Given this list of marker genes Tmem237, Zfp647 (NCBI Gene Id 239546), Per2, Itgal, Dock2, Ralb, Mycn, Lmo4, Chm, Lrmda, 5730471H19Rik, Arhgap30, Ppbp, Tuft1, Pdxk, Slc7a6, Kyat3, Cd27, Ccdc91, Wipf1, Pbx1, Cpq, Kctd11 (potassium channel tetramerisation domain containing 11), Cmtm7, Adamts20, Pde3b, Shmt1, Plp2, Lyplal1, Bcl7c, Tgm2, Bcl2l15, Tm6sf1, Siglecf, Zfp810, Rcn1, Lhfpl2, Mcpt4, Prtn3, Ttc8, Macroh2a1, Ptprs, Lgals1, Syk, Grb10, Tgfbr3 (transforming growth factor, beta receptor III), Ptprcap, Sqor, Slain1 (SLAIN motif family, member 1), Myct1, Arxes2, Pak1, Zc2hc1a (zinc finger, C2HC-type containing 1A), Cyfip2 (cytoplasmic FMR1 interacting protein 2), Plpp2, Nckap1l, Acap1, Nedd4l, Nqo2, Ptpn14, 4933431E20Rik, Bex6, Nr3c1, Nudt12, Lrrc56, Pdxp, Mndal, 4930403D09Rik, Nisch, AI504432, Celf2, Nubpl, Tmsb10, Pdlim1, Plxna2, Nck2, Pnpo, Lrch1, Prkd3, Cdc42ep3, Svil, Zfp979, Slc39a8, Dennd11, Ndst1, Rgs18, Cryl1, Ctbp2, Top1mt, 4933439C10Rik, Ube2e2, Hesx1, Cnn3, Fyn, Adgra3, Bex1, Rps6ka6, Cma1, Rcsd1, Ggh, Gk5, Gmfg, Tyrobp, Klhl5, Gp1bb, Cdip1 (cell death inducing Trp53 target 1), Iqgap2, Vim, Vegfb, Kctd14, Ift81, Zfp422, Gtf2ird1, Emb, Lrrc8d, E130307A14Rik, Dusp2, Mif (NCBI Gene Id 17319), Galnt7, Stap1, Smo, H2-DMa, Ptgr1, Arpc1b, Zfp704, Arrdc4, Zfp820, Fuca2, Bcr, Rgcc, Tjp2, Psmb9 (NCBI Gene Id 16912), Mei4, Septin11, Oosp2, Dock10, Ptprc, Lipa, Phpt1, Ptpn18, Lcp1, Sell, Ifi203, Prss50, Plac8, Runx3, Brca2, Eif4e3, Acot7, Skil, Pdgfd, Rgs19, Lats2 (NCBI Gene Id 50523), Spred1, Rassf5, Nlrc5, Hlf, Polr3g, Bckdhb, Slc25a13, Oaf, Susd2, Gm49083, Repin1, Il31ra, Mfsd6, Crlf3, Enc1, Sgpl1, Tpd52, Man2a2, Hook1, Ell2, Ralgps2, Ctps2, Capg, Marcksl1, Dcun1d4, Aqp11, Bmyc, Traf3, Arhgap15, Tspyl3 (NCBI Gene Id 99345), Bbs12, F5, Mpzl1, Phgdh, A630081D01Rik, Nab1, Rapgef2, Adgrg3, Magi3, 4930519L02Rik, Kifap3, Atxn10, F13a1, Gstm1, Gsta4, Mfsd13a, Pard6g, Ppp1r9a, Fchsd2, Nkg7, Tgif2, Cimap1b, Panx1, Mmd, Hk2, Bambi, Cbl, Sdc1, Socs5, Gng12, Lipo3, H1f0, Fkbp11 (FK506 binding protein 11), Alox12, Atxn1, Klhl22, Fkbp5, Sapcd2, Cd81, Pde4b, Smyd3, Endog, Dnmt3a, Zfp799, Rnf144a, Mob3a, Septin4, Syde2, Cdc14a, Gcnt2, Tspan3, Scml2, Slc25a4, Rhobtb3, Rmdn2, Plxnc1, Gimap6, Pitpnm2, Clec1b, Pde5a, Ggta1, Khdrbs3, Pdia2, Plcb4, Cntln, Krt10, Slc4a7, Kcnab2, Angpt1, Zfta, Tasl, Cenpw, BC035044, Cep68, Itgb3, Kctd1, Trib2, Homer2, Zfp455, Meis1, Adgrl2, Ccnd1 (NCBI Gene Id 12443), L3mbtl3, Ccl9, Tpk1 (thiamine pyrophosphokinase), Ctsc, Itprid2, Scmh1, Oxct1, Maoa, 4933405D12Rik, Ccnyl1, Smim36, Psmb8, Iftap, Tnfrsf13b, Fkbp1a, Smco4, Dock9, Gt(ROSA)26Sor, Ccdc122, Agpat2, Ltbp1, Dach2, Setmar, Itm2a, Cpne3, Gstt2, Atp8b4, Gpr171 (NCBI Gene Id 229323), Jcad, Ccdc69, Zfp518b, Igfbp4, Cavin2, Selplg, Rere, Limd2, Epb41l2, Mef2c, Gjb2, Fgfbp3, Sox4, Smim13, Ifngr1, Zkscan17, Satb1, Kctd12, Sh3tc2, Lclat1, Brpf3, Lst1, Itpr1, Hpcal1, Egfl7, Tns3, Slc38a1, Pxylp1, N4bp2l1, Ptpn3, Zfp2, Tspan6, Tdrkh, Il1bos, Hoxa9, Rsad1, Wwc2, Zscan18, Cnn2, Dnmt3b, Ctdspl, Pdia5, Ube2d1, Cd34, Slc6a13, Igf2bp3, Hmga2, Ncf2, Septin6, Map4k4, here is a description of the gene set: from publication Torchia EC, Boyd K, Rehg JE, Qu C, Baker SJ (PMID 17875932) studied in species Mus musculus EWS/FLI-1 is a chimeric oncogene generated by chromosomal translocation in Ewing tumors, a family of poorly differentiated pediatric tumors arising predominantly in bone but also in soft tissue. The fusion gene combines sequences encoding a strong transactivating domain from the EWS protein with the DNA binding domain of FLI-1, an ETS transcription factor. A related fusion, TLS/ERG, has been found in myeloid leukemia. To determine EWS/FLI-1 function in vivo, we engineered mice with Cre-inducible expression of EWS/FLI-1 from the ubiquitous Rosa26 locus. When crossed with Mx1-cre mice, Cre-mediated activation of EWS/FLI-1 resulted in the rapid development of myeloid/erythroid leukemia characterized by expansion of primitive mononuclear cells causing hepatomegaly, splenomegaly, severe anemia, and death. The disease could be transplanted serially into naïve recipients. Gene expression profiles of primary and transplanted animals were highly similar, suggesting that activation of EWS/FLI-1 was the primary event leading to disease in this model. The Cre-inducible EWS/FLI-1 mouse provides a novel model system to study the contribution of this oncogene to malignant disease in vivo. Mouse Gene Set: TORCHIA_TARGETS_OF_EWSR1_FLI1_FUSION_DN Genes down-regulated in leukemic progenitor cells expressing activated fusion of ESWR1 and FLI1 compared to normal hematopoetic progenitors.